The following is a description of a gene set: Reactome Pathway: The role of GTSE1 in G2/M progression after G2 checkpoint studied in species Homo sapiens part of: G2/M Transition GTSE1 (B99) was identified as a microtubule-associated protein product of the mouse B99 gene, which exhibits both a cell cycle regulated expression, with highest levels in G2, and DNA damage triggered expression under direct control of TP53 (p53). Human GTSE1, similar to the mouse counterpart, binds to microtubules, shows cell cycle regulated expression with a peak in G2 and plays a role in G2 checkpoint recovery after DNA damage but is not transcriptionally regulated by TP53.<p>In G1 cells, GTSE1 is found at the microtubule lattice, likely due to direct binding to tubulin. An evolutionarily conserved interaction between GTSE1 and MAPRE1 (EB1), a microtubule plus end protein, promotes GTSE1 localization to the growing tip of the microtubules, which contributes to cell migration and is likely involved in cancer cell invasiveness. Highly invasive breast cancer cell lines exhibit high GTSE1 levels in G1, while GTSE1 levels in G1 are normally low. At the beginning of mitotic prometaphase, GTSE1 is phosphorylated by mitotic kinase(s), possibly CDK1, in proximity to the MAPRE1-binding region, causing GTSE1 dissociation from the plus end microtubule ends.<p>During G2 checkpoint recovery (cell cycle re-entry after DNA damage induced G2 arrest), GTSE1 relocates to the nucleus where it binds TP53 and, in an MDM2-dependent manner, promotes TP53 cytoplasmic translocation and proteasome mediated degradation. Relocation of GTSE1 to the nucleus in G2 phase depends on PLK1-mediated phosphorylation of GTSE1.<p>GTSE1-facilitated down-regulation of TP53 in G2 allows cells to avoid TP53 mediated apoptosis upon DNA damage and to re-enter cell cycle. While TP53 down-regulation mediated by GTSE1 in G2 correlates with decreased expression of TP53 target genes involved in apoptosis and cell cycle arrest, GTSE1 can also increase the half-life of the TP53 target p21 (CDKN1A). GTSE1-mediated stabilization of CDKN1A involves interaction of GTSE1 with CDKN1A and its chaperone complex, consisting of HSP90 and FKBPL (WISp39), and may be involved in resistance to paclitaxel treatment., and this is the list of marker genes: PSMC5, PSMC4, TUBB1, PSMD13, PSMC2, TUBB4A, PSMD7, PSMD1, PSMC1, PSMD8, CCNB2, TUBA3D, UBC, TUBB2B, TUBA4A, TUBB6, TUBA1A, PSMD14, TUBB2A, TUBB8B, MAPRE1, HSP90AA1, PSMB3, PSMD12, PSMA1, TUBB3, PSMD6, TUBA1C, PSMA2, RPS27A, PSMB7, TUBA4B, HSP90AB1, PSMB6, TUBA8, PLK1, PSMA5, UBB, CDK1, TUBAL3, PSMA3, PSMB5, PSMA7, CDKN1A, SEM1, TUBA3C, PSMB4 (proteasome 20S subunit beta 4), UBA52, PSMD2, PSMB1, PSMA6, ADRM1, PSMC6, PSMA4, PSMC3, TUBB4B, TUBB8, PSMD3, TUBA3E, TP53, CCNB1, PSMB2, GTSE1, PSMD11 (NCBI Gene Id 5717), TUBA1B, FKBPL